The following is a description of a gene set: species: Homo sapiens Human Gene Set: GOBP_SPINDLE_ORGANIZATION A process that is carried out at the cellular level which results in the assembly, arrangement of constituent parts, or disassembly of the spindle, the array of microtubules and associated molecules that forms between opposite poles of a eukaryotic cell during DNA segregation and serves to move the duplicated chromosomes apart., and this is the list of marker genes: CCNB2, DRG1, SENP6, CHEK2, GPSM2, STAG1, TUBB1, CSNK1D, STMN1, SBDS, PDE4DIP, TTK, DCAF13, PDCD6IP, SPAST, INTS13, HSPA1B, MZT1, GOLGA2 (golgin A2, NCBI Gene Id 2801), GNAI1 (NCBI Gene Id 2770), CEP192, SUGT1, KNSTRN, KIF2A, RCC1, VCP, SKA1, LSM14A, INO80, HAUS8, PSRC1, ILK, NEK2, CEP72, CEP126, PTEN, BCCIP, NUP62, CHMP6, RHOA, HAUS5 (NCBI Gene Id 23354), TPR, TNKS, SPAG5, PKD1, WDR62, TUBGCP6, UVRAG, EZR, TUBGCP4, ABRAXAS2, MYH9, POLDIP2, CHMP7, CHMP2A, CEP63, MAP10, TUBG2, HAUS2, PPP2R1B, MLH1 (NCBI Gene Id 4292), KIFC1, MAPRE1, TUBGCP2 (NCBI Gene Id 10844), NUF2, PLK5, HAUS4, POC1A, CDC20, CCDC66, HAUS6, PCNT, MAP1S, ZNF207, CLASP2, EFHC1, TBCE, TUBG1, AURKB, ABRAXAS1, DCTN6 (dynactin subunit 6), RGS14, LIMK2, MAP9, SMC3, BORA, INCENP, PRC1, CHMP4B, CCNB1, STARD9, ANKRD53, SPC25, CENPJ, SKA2, SEPTIN1, NTMT1, SAC3D1, CHMP3, NEK6, TPX2, BIRC5 (NCBI Gene Id 332), CLASP1, SKA3, STIL, NUMA1, SPICE1, CHMP4A, MAPRE3, TACC3, NDC80, RNF4, DDB1, TUBB, RIPOR2, SMC1A, AAAS, TPPP, CEP120, CLTC, ASPM, KPNB1 (NCBI Gene Id 3837), EML1, BCAS2, CHMP2B, TACC2, UHRF1, EML3, TUBB8, NCOR1, CKAP5, MAPRE2, HNRNPU, AURKC, PIBF1, RMDN1, KIF23, SASS6, HAUS1, ARHGEF10, PLK2, AFG2B, STAG2, OFD1, CHMP1A, TUBGCP5, DCTN1, PTPA, RANGRF, DLG1, AURKA, FLNA, CDCA8, MAPK15, ATRX, RACGAP1 (NCBI Gene Id 94651), HAUS7, TUBGCP3, LZTS2, VPS4B, HSPA1A, ESPL1, DCTN2 (dynactin subunit 2), CCDC69, MAP4, HAUS3, RAN, KIZ, PARP3 (NCBI Gene Id 25908), FSD1, TACC1, HDAC3, CEP97, KIF4A, CCSAP, CENPE, MYBL2, MOS, RAE1, DYNC1H1, KASH5, RAB11A, CHMP5, PPP2R1A, TRIM36 (tripartite motif containing 36), KIF4B, KIF15, PLK3, KIF3B, DLGAP5, FAM110A, AUNIP, CHMP4BP1, WASHC5, PLK1, CCDC61 (NCBI Gene Id 732172), KIF11, FBXO5, RPS3, CHMP1B, NUDC, MISP, GTF2B, CHD3, PRICKLE1, CENPH, SUN2, CHMP4C (charged multivesicular body protein 4C), WRAP73, NEK7